Given this list of marker genes TJP3, VEGFA, TRPV4, ANGPT1, PDE3A, VEGFB, UCN, BMP6, TACR1, TJP1, PDE2A, TJP2 (tight junction protein 2), FGFBP3, APOE, OCLN, TACR2, PTP4A3, TGFB1, here is a description of the gene set: species: Homo sapiens Human Gene Set: GOBP_POSITIVE_REGULATION_OF_VASCULAR_PERMEABILITY Any process that increases the extent to which blood vessels can be pervaded by fluid.